Given this list of marker genes ARNT, RBMS1, ZNF385A, BMPR2, BCL6, FNDC5, TBC1D15, SUN2, DUSP10, PAX2, VCP, FBXW7, IGIP, SOX4, GFRA2, YAF2, PHF21A, EFNB2, AGAP1, MARCKSL1, AMD1, MEIS1, ABCC5, NUFIP2, NRXN2, SP8, DDX6, ZNF281, DLX2, PDS5A, ARL5A, CXCL5, HOXC4 (NCBI Gene Id 50712), ZNF609, NR3C2, RAB21, ZFP36L1, MEIS2, ETS1, ACSL4, ZMAT2, SEC14L1, SYT1, ZFX, STOX2, MYT1L, SLMAP, ANKS1B, HIC2, BCLAF3, PPP1R12A (NCBI Gene Id 4659), TAOK3, EPHB1, NR2C2, IGSF22, SLBP, NRG2, FAM13B, SOX2, JAG1, DAB2IP, ISL1, DLGAP2, BPTF, PIEZO2, ZNF608, EPHA8, MARCHF5, HNRNPA1 (NCBI Gene Id 780920), CDC42EP3, ITGA6, VPS26A, PDZRN4, SP3, DDX3X, SIAH1, SLC25A27, MED13L, SLTM, EFL1, STAT5B, OXR1 (NCBI Gene Id 55074), RPS6KB1, BACH2, UBE2R2, CHD7, XKR4, IRF2BPL, ZMYM5, PITPNB, FIGN (NCBI Gene Id 80249), SFMBT1, PDLIM5, PCDH7, NIPBL, ILF3, AP3B1, TP53INP1, ZBTB10, AGAP4, KDM1B, USP6, PIK3R1, SBK1, MATR3, TSHZ1, CAMTA1 (NCBI Gene Id 23261), SCN8A, MED26 (mediator complex subunit 26), SLC17A6, KCTD1, HERC4, HOXC10, PRDM1, TGIF2, GLYR1, PTPRZ1, FHIP2A, NKAIN2, ING3, GNAZ, TRIO, GRM7, CIB2, PRKCB (protein kinase C beta), NR4A2, TOX, APC, ADGRL3, GALNT1, SH3KBP1, DNAJC13, TENT4B, CBX7, C14orf28, EIF4G3, NPEPPS, FMR1, PAX6, RSBN1, JAKMIP3, CACNG2, HMGB1, PLCG1, NEBL, PEG3, CELF2, ETV1, PSMA7, CEP192, CELF4, KLHL32, PTP4A1, DOCK3, MAN1A1, ACTN1, ARK2C, CTNND1, BTBD10, LMNA, RBMS3, NFXL1, ATP2B4, TMTC4, KDM2A, HNRNPK, GABBR2, ESRRG, RUNX1T1, HNRNPA1L2, PSD3, PHF12, C11orf65, SP4, SP100 (SP100 nuclear antigen), RUNX1, EFR3A, PAPOLB, PMEPA1, PITPNA, SGMS1, AGO3, LSM12, YWHAH, EP300, here is a description of the gene set: Genes having at least one occurence of the motif GCAAAAA in their 3' untranslated region. The motif represents putative target (that is, seed match) of human mature miRNA hsa-miR-129 (v7.1 miRBase). Human Gene Set: GCAAAAA_MIR129 species: Homo sapiens